The following is a description of a gene set: Genes predicted to be targets of miRBase v22 microRNA hsa-miR-4540 in miRDB v6.0 with MirTarget v4 prediction scores > 80 (high confidence targets). studied in species Homo sapiens Human Gene Set: MIR4540 from publication Chen Y, Wang X (PMID 31504780), and this is the list of marker genes: HMGCR, MGAT5B, EIF4A2, PARG, ACBD5, DSTYK, HTR2C, KMO, PTPN12 (protein tyrosine phosphatase non-receptor type 12), CENPI, PLEKHH1, EEF1E1, CHIC1, RHOG, CPSF7, CXCL16, GLO1, MYLK, ELK4, DNAJC25, URI1, MMP20, GABRB2, NADK2, PDE7A, NNT, ETF1, MANEA (NCBI Gene Id 79694), ABHD3, VGLL3 (NCBI Gene Id 51159), LCE1C, GPAM, SNX13, PARL, PDE10A, HMGB1, WDFY1, PPP2R5A, MECOM, ZSWIM6, MCMDC2, PGAP2, SLIT2, RBM43, DDX21, CDK17, NRG1, RPS6KC1, POC1B, TYW3